Given this list of marker genes CCNJL (cyclin J like, NCBI Gene Id 79616), SFMBT2, PRRG3, ZDHHC15, TDRD5, MBD4, ILF3, HAP1, FBXO9, COL4A1, CDH6 (cadherin 6), ADGRL1, AP1M2, ARHGAP18, PRKCD, METTL8, TACC2, NOC2L, SMC5, PPM1B, FNBP4, ZBTB34, RASGRP2, KRT8, NR4A1, SEMA4A, CLCN5, C16orf90, PRKD3, CEP72, ARPP21, EGF, PYGM, ZNF2, GDPD3, FES, NRP2, SMARCAD1 (NCBI Gene Id 7303), RASL11B, C11orf96, SKI (SKI proto-oncogene), RREB1, EHMT1, UBQLN4, PCSK1, DDX1, SLC45A3, RPRD1A (NCBI Gene Id 55197), NDRG2, ITIH5, MCF2L, LRATD2, PLCG1, CDC42BPG, RAD9B, PHF7, STMN1, TCF7L2, GCHFR, TRAK2, DNAI1, CAMK2N1, GLT8D2, ITGB1BP2, TCERG1, GALNT16, FIBCD1, DCBLD2, CPNE9, CENPJ, TMEM131L, ABCD3, DZIP1, CAPN8, TPSB2, DYNC2H1, CTSH, SLC12A6, CCNJ, TTC3, TRPM1, FMNL3, ACER2, ABTB3, METTL13, PARP9, DLG3, SPATS2L, WDHD1, SYT12, H2AB2, LRIG3, DNMT3A, KCNMB4, KLHL4, CDK6, CTSW, ITK, RIGI, HNRNPA1, SLC30A10, SETDB1, SYDE2, NHLRC3, RASL10B, MPI, TBC1D4, NTN1 (NCBI Gene Id 9423), C1QL3, STK26, LUM, FBXO31, ZBED6, ACTN2, DNAH8, NRIP1, IL17RA, DGKD, ZNF131, KDM1A, NEDD4L, TLK1, NQO2, NUP155, RAB3IP, PPP1R1A, NR4A3, PFAS, IRAG2, TUBB, SOX4, TCEANC, BTK, GSAP, RUFY3 (NCBI Gene Id 441022), CXCL9, WDR86, CDK2, BAZ2B, TMEM132A, ACTN1, ZFTA, PANX2, ZNF219, IKZF3, VSX2, FOXRED1, PARP11, PLCXD2 (NCBI Gene Id 257068), CTPS1, ANKRD23, ECHDC3, FZD8, GDNF (NCBI Gene Id 2668), DYNC2I1, DCAF17, SLC22A17, NRBP1, COG3 (component of oligomeric golgi complex 3), ZMYM3, DUSP5, TIA1, ADCY6, EVI5L, ZMYND12, MAGOHB, ARV1, CD207, N4BP2, ARHGEF28, AQP11, SLC16A6, NARF, ATPAF2, TSC22D1, GALC, KCNQ5, KRT6A, GSTM5, AAAS, BASP1, BCLAF1 (BCL2 associated transcription factor 1), TMEM59, CDIPTOSP, PTPRU, SLC7A6, SH3BP5L, SMC3, RTN4RL1, MSL1, RAG1, TM6SF1, MEGF6, PRAM1, KTN1, GFI1, LENG8, ADD1, KIAA1549L, TNIK, here is a description of the gene set: Human Gene Set: GSE40274_FOXP3_VS_FOXP3_AND_LEF1_TRANSDUCED_ACTIVATED_CD4_TCELL_DN from publication Fu W, Ergun A, Lu T, Hill JA, Haxhinasto S, Fassett MS, Gazit R, Adoro S, Glimcher L, Chan S, Kastner P, Rossi D, Collins JJ, Mathis D, Benoist C (PMID 22961053) The transcription factor FoxP3 partakes dominantly in the specification and function of FoxP3+ CD4+ T regulatory cells (Tregs), but is neither strictly necessary nor sufficient to determine the characteristic Treg transcriptional signature. Computational network inference and experimental testing assessed the contribution of several other transcription factors (TFs). Enforced expression of Helios or Xbp1 elicited specific signatures, but Eos, Irf4, Satb1, Lef1 and Gata1 elicited exactly the same outcome, synergizing with FoxP3 to activate most of the Treg signature, including key TFs, and enhancing FoxP3 occupancy at its genomic targets. Conversely, the Treg signature was robust to inactivation of any single cofactor. A redundant genetic switch thus locks-in the Treg phenotype, a model which accounts for several aspects of Treg physiology, differentiation and stability. studied in species Homo sapiens Genes down-regulated in CD4 T conv over-expressing: FOXP3 versus LEF1 and FOXP3.